Given this list of marker genes Gsto1, Rtn4rl2, Matn3, Col4a1, Itih3, Dcn (NCBI Gene Id 13179), Frem2, Lgals1, Tsku, Loxl4 (NCBI Gene Id 67573), Adamts2, Smoc2, Mmp14, Ang4, Gpc5, Fgf1, Dmbt1, Mfap1b, Adamtsl2, Try4, Tgfb3, Gpc2, Angpt2, Gh, Mmp25, Smc3, Lamb1, Anxa9, Itih1, Col18a1, Calr, Lgals4, Adamts19, Hcfc1, Mamdc2, Npnt, Frem1, Enam (enamelin), Spon1, Fgfr2, Clec14a, Vcan, Lrrc17, Gpld1, Col26a1, Fn1, Mmp1a, Adamts15, Serpinh1 (serine (or cysteine) peptidase inhibitor, clade H, member 1), Anxa6, Tfip11, Col1a1, Ctsd, Ihh, Mfap2, Otog, Lama3, Itgb4, Mmp19, Dag1, Lama1, Ambp, Mmp9, Loxl1, Hrg, Anxa3, Serpine2, Tecta, Lama2, Sspo, Anxa1, Prg2, Rpsa, Vwa5a, Col9a3, Spn, Ctsl, Sned1, Ndnf (NCBI Gene Id 68169), Defb22, Otol1, Fgg, Tnc, Matn2, Serac1, Lrrn1, Scara3, Reg3b, Hmcn1, Serpina3k, Cstb, Col5a3, Optc, Zan, Nid1, Wnt5b, Ecm2, Adamts5, Prg4, Tgfb2, Anxa11, Vegfa, Nepn, Col4a2, Agrn, Matn4, Adamts18, Serpinb6a, Tril, Ambn, Pcolce2, Lamc1, Col3a1, Col10a1, Thsd4, Itln1, Col4a3, Lrig1, Vwa2, Alb (albumin), Tnfrsf11b, Pxdn, 2300002M23Rik, Mepe, Cd151 (CD151 antigen), Chadl, Eln, Chad, Adamts1, Reg3g, Sod3, Myoc, F2, Vwa1, Reln, Plxnb2, Igf2, Elfn2, Mmp16, Sftpa1, Plod2, Timp3, Itih5, Plxna2, Mmp3, Angpt1, Adamtsl3, Lgals9, Egfl7, Igfbp6, Cask, Wnt6, Col5a2, Loxl2, Tspan9, Clic3, Lamc2, Gpc4 (NCBI Gene Id 78622), Sema6d, Tnr, Hspg2, Adam19, Muc1, Ush2a, Fgl1, Mfge8, Loxl3 (lysyl oxidase-like 3), Pcsk6, Lingo2, Lingo4, Rell2, Lgalsl, Vwc2, Cpn2, Plod1, Reg2, Mmp13, Col25a1, Thbs2, Zp1, Clu, Fbln5, S100a10, Col20a1, Sparcl1, Lrrc3b, Lamc3, Vtn, Ctsz, Wnt4, Col6a3, Lox, Pkhd1l1, Serpinb1a (serine (or cysteine) peptidase inhibitor, clade B, member 1a), Fgl2, Trf, Itgb1, Ptn, Muc5ac, Bmp1, Entpd2, Plscr1, Oc90, Ntn5, Apoe, Rbp3, Snorc, Prss34, Ntn1, Muc6 (NCBI Gene Id 353328), Dspp, Mmp2, Sparc, Amtn, Svep1, Tinagl1, Col6a6, Fcnb, Mmp21, Col1a2, Mmp12, Bmper, Cela1, Tinag, Adamts3, Serpina1a, Muc4, Wnt7a, Insl5, Papln, Angptl3, Mfap5, Nyx, Nphs1, Adamtsl5, Thbs1, Lingo1, Fga, Col24a1, Serpini2, Megf9, Lrrn2, Fgf10, Efemp1, Efemp2, Spock3, Col15a1, Prelp, Lrrc32, S100a13, Pf4, Efna5, Ltbp4, Runx1 (runt related transcription factor 1), Fam20b, Rarres2 (NCBI Gene Id 71660), Comp, Ogn, Abi3bp, Serping1, Fmod, Fras1, Vasn, Lrrn3, Omd, Thbs3, Smoc1, Ccbe1 (collagen and calcium binding EGF domains 1), Coch, Col7a1, Timp2, Lama5, Itih4, Ang, Adamts9, F3 (NCBI Gene Id 99486), P3h1, Aspn, Slit2, Plscr2, Angptl7 (NCBI Gene Id 654812), Hapln3, Vit, Sftpb, Zg16, Ang6, Colec12, Col28a1, Timp4, Anxa4, Col6a2, Itga6, Elane, Angptl2, Mfap1a, Amelx, Lad1 (ladinin), Egflam, Tgfb1, Col11a2, Adamtsl4, Ltbp1, Tgm4, Anxa5, Tgfbi, Bgn, Cfdp1, Col23a1, Spock2, Fcgbp, Anxa7, Muc5b, Col8a1, Mmp8, Col11a1, Adam10, Fbn2, Fbln1, Marco, Otogl, Adamts16, Hapln1, Col4a4, Col19a1, Muc2, Col14a1, Col6a5, Lgr6 (NCBI Gene Id 329252), Nav2, Serpinf1, Tnxb, Pzp, Mmp7, Clec3b, Igfbpl1, Gpc1, Ltbp2, Fgf9, Lingo3, Il16, Angptl6, Fibcd1, P3h2, Phospho1, Itih2, Adamts13, Col4a5, Olfml2b (NCBI Gene Id 98377), Cpz, Lama4, Mmp1b, Postn, Lrrc15, Dpt, Mmp24, Tnn, Ovgp1, Ang5, Ctsb, Hpse, Igf1, Fcna, Impg2, F13a1, Mmp11, Epyc, Pmp22, Ang2, Ccn4, Vwf, Crispld2, Rtbdn, Wnt3, Mmp15, Col6a4, Lamb2, Lgals3, Wnt2 (NCBI Gene Id 93808), Lrrtm1, Col27a1, Lrrtm3, Col4a6, Reg1, Prss2, Ncan, Ccdc80, Ache (acetylcholinesterase), Mmrn2, Col13a1, S100a6, Krt1, Ucma, Olfml2a, Ccn5, Acan (NCBI Gene Id 11595), Plod3 (procollagen-lysine, 2-oxoglutarate 5-dioxygenase 3), Mmrn1, Pkm, Mmp17, Srpx2, Ntn3, Ptprz1, Fgb, Hpse2, Ccn3, Ahsg, Adamts6 (NCBI Gene Id 26551), Sftpd (NCBI Gene Id 20390), Megf6, Dlg1, Mmp23, Emilin1, Mfap4, Cela3b, BC037156 (cDNA sequence BC037156), Angptl1, Frem3, Hapln2, Ssc5d, S100a11, Col2a1, Ntn4, Ndp, Ins1, Hnrnpm, Ngly1, Dmp1, Entpd1, Adamts12, Gpc3, Adamts17, Bmp7, Cd180, Igfbp7, Tgm3, Adamts7, Spon2, Serpinc1, Bcan, Lrrc24, Timp1, Elfn1, Zp3 (NCBI Gene Id 22788), Col9a1, Col22a1, Cela2a, Kazald1, Fcgbpl1, Colq, Wnt5a, Lrig2, Lman1, Adamts20, Tgm2, Thbs4, Adamts8, Glg1, Lrrc3c, Adamts14, Tectb, Ccn6, Cst3, Cspg4, Serpinf2, Acta2, Shh, Fbln7, Plg, Ins2, Adamtsl1, Nid2, Col5a1, Fbn1, Mmp10 (NCBI Gene Id 17384), Gpc6, Hapln4, Fbln2, Sema3c, S100a3, Angpt4, Col12a1, Ctsc, Gfod2, Col8a2, Hsd17b12, Zp2, Htra1, Col16a1, Plxdc2, Ecm1, Ptx3, Lamb3, Emid1, Hsp90aa1, Ccn2, Ltbp3, Mmp20, Gp1ba, Serpine1, Hmcn2, Matn1 (matrilin 1, cartilage matrix protein), Adamts4, Cilp, Anxa2, Podnl1, Cthrc1, Sfrp1, Adamts10, Angptl4, Lum, Lrrtm4, Wnt11, Alpl (alkaline phosphatase, liver/bone/kidney), Col6a1, Col17a1, Mgp, Egfl6, Kng1, Emilin2, Ccn1, Col9a2, Impg1, here is a description of the gene set: Mouse Gene Set: GOCC_EXTERNAL_ENCAPSULATING_STRUCTURE studied in species Mus musculus A structure that lies outside the plasma membrane and surrounds the entire cell or cells. This does not include the periplasmic space.